The following is a description of a gene set: from publication He P, Lim K, Sun D, Pett JP, Jeng Q, Polanski K, Dong Z, Bolt L, Richardson L, Mamanova L, Dabrowska M, Wilbrey-Clark A, Madissoon E, Tuong ZK, Dann E, Suo C, Goh I, Yoshida M, Nikolić MZ, Janes SM, He X, Barker RA, Teichmann SA, Marioni JC, Meyer KB, Rawlins EL (PMID 36493756) species: Homo sapiens Human Gene Set: HE_LIM_SUN_FETAL_LUNG_C1_INTERM_NEUROENDOCRINE_CELL Interm neuroendocrine, and this is the list of marker genes: KIF1A, RNF128, TMEM169, ROBO2, CBFA2T3, DUSP26, MS4A8, DACH1, IZUMO4, FGF14, ABCA5, GNAO1, KSR2, PROC, RFX6, GPBAR1, RAB26, GIPR, TMOD2, SLC39A14, OPTN, GHRL, BRSK2, CADM2, BAIAP3, KCNJ6, LINC00261, CDHR3, CNIH2, CHGA, KCNMB2, KLK11, LYST, SLC38A11, DPP10, DDC, LINC01315, PGAM2, INHBA, MAPK8IP1, HIVEP3, TOX, BICDL1, ARK2C, CD200, SRRM4, MATN2, CADPS, HEPACAM2, DNER, PTPRN, ADGRG1, LY6H, JAM3, STMN3, ICA1L, ATP2A3, RTN1, PLAC8, POU2F2, NCAM1, WFS1, RASA4B, ADAM28, CFAP65, KL, CACNB2, ELAPOR1, RAB3B, CAMK1D, SRRM3, OTULINL, C21orf58, APLP1, KCNH6, FSTL5, RGS7, CACNA2D1, BCL2, GPX3, RGS4 (regulator of G protein signaling 4), MIR7-3HG, PRUNE2, NDRG4, CELF3, MAP1B, RIC3, SEMA3A, BAALC, CEACAM1, GDAP1, ACTL6B, CNTNAP2, INHBB, RAB3C, UNC79, TTLL7, CASZ1, DUSP4, HTR2C, ABCC8, INSM1, SYT5, VSTM2L, TMEM176B, KIAA0930, RHBDL1, RIMBP2, NPDC1, RASD1, DLL4, NACAD, DEPP1, STXBP1, MAPRE3, MIAT, PSD, SCGN, MTMR7, REEP2, ARHGEF26, SLIT1, KLHL32, RAP1GAP2, CHN2, RUNDC3A, LRATD2, ANK2, WDR17, DPYSL3, ELAVL4, SYT7, SLC12A5, SNAP25, STX1A, MMP25-AS1, GCH1, CTTNBP2, SV2C, THSD4, CLIP3 (CAP-Gly domain containing linker protein 3), SLC29A4, RUNX1T1, TMEM178A, MARK1, ADCY2, BIK, DNAJC12, ANKH, STK32A, PALM, TMPRSS3, PPP1R1A, TUBB3, CACNG4, SIX1, EYA4, NEGR1, CA8, PCSK2, PTPRN2, CRH, ROBO1, COL12A1, TECPR1, CRMP1, ST18, PDZRN3, PCSK1, RGS11, ADCY1, NEUROD1, FAM110B, SCG5, KCNB2, RIMS2, CFC1, KIF19, MAP2, NAAA, GPRIN3, CACNA1H, RGS17, SYT13, SCG3, SLC7A4, CCDC28B, SMOC1, STXBP5L, SEZ6L2, TRNP1, KCNH2, TCERG1L, CACNA1A, SV2A, VWA5B2, SST, SYT11, BTBD17, AMPH, TMEM176A, A4GALT, PLPPR2, SPTBN2, PCDH17, SCG2, DCX, HES6, CAMK2B, NLRP1, NKX2-2, SLITRK6, ACSL1, CDCP1, DACH2, ST6GALNAC5, DOP1B, RPRM, CLDN5, SGSM1, TMEM51, PROX1, CFC1B, BACE1, DLL3, MAPK8IP2, AK5, SYT14, STMN2, SCAMP5, TACC2, CHGB, MOXD1, SETBP1 (SET binding protein 1), ARFGEF3, SYP, KLK12, ASCL2, GPR160, GNG2, SMPD3, ASCL1, NOL4, MAP6 (NCBI Gene Id 85299), QPCT, PCLO, NAP1L5, NEURL1, DRAIC, NRXN1, NAV1, LONRF2 (LON peptidase N-terminal domain and ring finger 2), CXXC4, TOX3, HSPA2, DST, GRP, RASA4, GABRB3, NPM2, TAGLN3, SCN3A, AP3B2, SYT4, RCOR2, SSTR2, JAKMIP2, TP53INP1